Given this list of marker genes ANXA5, TMEM121B, SELENOK, C12orf75, EIF2S2 (eukaryotic translation initiation factor 2 subunit beta), TMT1A, RIN3, NUCB2, TBCB, ZNF511 (zinc finger protein 511), DYNLRB1, RAB32, CPA3, ERO1A, SDHB, RAB5IF, LIPA, EIF5A, ALDH18A1, ITGB7, SUCLG1, PRKAR2B, IL13RA1 (interleukin 13 receptor subunit alpha 1), MKKS, FGFR2, LSP1, NDUFB5 (NADH:ubiquinone oxidoreductase subunit B5), SEC11C, ETHE1 (NCBI Gene Id 94930), ANXA2, SEMA4C, BEX3, BNIP3, TMED2, URI1, PPA1, ACOT7, NAP1L3, JAM2, DDX46, HSD17B12, WAPL, TOP1MT, CTSG, PRTFDC1, SLC22A15, NDUFA12, RAB11FIP1, LDAF1, HERPUD1, RPN2, SMIM27, GRN, ERG28 (ergosterol biosynthesis 28 homolog), SIRPA, CCSAP, TREM1, KRTCAP2, SLC2A4RG, CLDN10, ASAH1 (NCBI Gene Id 79795), TNFSF13, PALLD, NCOR2, TNFAIP2, DOCK5, CASP1, TXNL4A, PRDX4, PSMB1, HOPX, RNF135, ADA2, EPRS1, DAD1, PGRMC1, EEF1AKMT2, TIMM50, LAPTM4B, AK2, THEM4, PRR14, VPS29, TYROBP, SPIRE1, CTSA, COX6A1, CSF1R (NCBI Gene Id 8156), HSBP1, SPATS2L, ACAP1, RAN, CANX, MICOS10, MAP3K21, GXYLT2, S100A6, SMIM20, CDC123, MAPKAPK3, COMMD8, PIGY, MRPS23, FAS, RBPMS, SLA2, STARD3NL, PNP, STEAP3, FOCAD, SLC35F2, TLE3, ALCAM, ATG101, NPC2 (NPC intracellular cholesterol transporter 2), SPCS1, PARK7, GLIPR2, C9orf43 (chromosome 9 open reading frame 43), DYM, CORO1C, SFXN3, PTPN7, AIG1, DCXR, MRPL48, CST3, S100B, MRPL27, PLAGL1, PLAUR, P2RY2, ATP5MJ, KCNK17, MRPS33, SAMSN1, EEF1B2, SBNO1, TPP1, EXOSC7, LAP3, EEF1E1, KLF11, PIGK, HEXB, JAML, GGCX, TM2D2, SNX5, APLP2, AVPI1, CNNM2, HADH, HENMT1, FCER1G, PRAM1, MRPL20, SIGLEC5, IMPA2, BIVM, POLR2K, COTL1, ANKRD27, ATP5PO, ELF4, IFI27L1, SAMHD1, TNRC18, ALKBH2, SCRN1, GNPTG, ANXA2P2, CD84, RPS8, C1orf162, PYGL, TSTD1, GOLGA8H, IFTAP, CD93, SPINT2, EBNA1BP2, RPL22, LAMTOR2, SEMA4A, ZYX, ARPC2, NUP210, OST4 (oligosaccharyltransferase complex subunit 4, non-catalytic), ATP5MK, PTPRS, CFL1, BACE1, CDC45, TMEM258 (NCBI Gene Id 746), APEX1, ARHGEF40, LRPAP1, UGCG, MAN2B1, here is a description of the gene set: IL-10 regulates anti-inflammatory signaling via the activation of STAT3, which in turn controls the induction of a gene expression program whose products execute inhibitory effects on pro-inflammatory mediator production. Here we show that IL-10 induces the expression of an ETS family transcriptional repressor, ETV3 and a helicase family co-repressor, SBNO2 (Strawberry notch homolog 2) in mouse and human macrophages. IL-10-mediated induction of ETV3 and SBNO2 expression was dependent upon both STAT3, and co-stimulus through the TLR pathway. We also observed that ETV3 expression was strongly induced by the STAT3 pathway induced by IL-10 but not STAT3 signaling activated by IL-6, which cannot activate the anti-inflammatory signaling pathway. ETV3 and SBNO2 specifically repressed NF-kB-mediated transcription and can physically interact. Collectively our data suggest that ETV3 and SBNO2 are components of the pathways that contribute to the downstream anti-inflammatory effects of IL-10. We compared expression profiles of macrophages isolated from IL-10 -/- mice. Macrophages were treated with either LPS or LPS plus IL-10. Treatment times were 10, 20 and 30 minutes. Genes up-regulated in macrophages with IL10 knockout treated by LPS: 10 min versus 30 min. from publication El Kasmi KC, Smith AM, Williams L, Neale G, Panopoulos AD, Watowich SS, Häcker H, Foxwell BM, Murray PJ (PMID 18025162) species: Homo sapiens Human Gene Set: GSE9509_10MIN_VS_30MIN_LPS_STIM_IL10_KO_MACROPHAGE_UP